The following is a description of a gene set: studied in species Homo sapiens Genes up-regulated in comparison of plasmacytoid dendritic cells (pDC) from influenza vaccinee pre-vaccination versus those at day 7 post-vaccination. from publication Nakaya HI, Wrammert J, Lee EK, Racioppi L, Marie-Kunze S, Haining WN, Means AR, Kasturi SP, Khan N, Li GM, McCausland M, Kanchan V, Kokko KE, Li S, Elbein R, Mehta AK, Aderem A, Subbarao K, Ahmed R, Pulendran B (PMID 21743478) Systems vaccinology has emerged as an interdisciplinary field that combines systems wide measurements and network and predictive modeling applied to vaccinology. Here we used the systems vaccinology approach to study the molecular mechanisms underlying th Human Gene Set: GSE29618_PRE_VS_DAY7_POST_LAIV_FLU_VACCINE_PDC_UP, and this is the list of marker genes: NRAP, MYH15, ALAS2, ALDH3A1, SERPINE1, FOXB1, CETN1, MUC13, ACVR2B-AS1, ZNF80, DSG1, MCOLN3, CLCN4, PDE7B, DHX58, NTRK2 (NCBI Gene Id 4915), SDF4, MEST, KIR2DL2, CD1E, LMX1B, HTR2C, MSMB, PRND, RNF126P1, CAV2, KCNIP2, SEZ6L2, DGKG, SPAG1, EDA2R, CYSLTR2, NEUROG2, ST20 (suppressor of tumorigenicity 20), LARP6, SOX10, GRB10, GPR135 (NCBI Gene Id 64582), LRRTM4, MPL, SMG6, CA3, AQP1, ZKSCAN5, EN1, AGR2, AFAP1, VPREB3, REPS1, HCG9, LYZL6, STAB2, FADD, ECM2, KIF25, PREP, PCGF1, PRDM14 (NCBI Gene Id 63978), IL17B, ARAP3, ROBO1, TMSB4Y, AMDHD2, ST8SIA1, CLUHP3, STC2, PALM, CEND1, BRINP1, SHANK2, ELL, THY1, ALX3, CYB561, HOXB7, ICOS, GNG3, WT1, LGALS14, CCL8, OR2B6 (NCBI Gene Id 26214), PER3, CPN1, GNAT3, HOXA5, PARP16, CDA, PRTN3, SIX5 (NCBI Gene Id 1754), F9, MAP3K9, LIFR, CACNG3 (NCBI Gene Id 10368), ACVR2B, IL1RAP, CCL21, EREG (NCBI Gene Id 2069), FXR2, GNAT1, HTN3, RAI14, DIRAS2, UBXN6, OR2C1 (NCBI Gene Id 81101), KCTD14, PRR5, KALRN, RAPGEF4, DHRS2, MCF2L, S100P, YBX2, FSCN2, IGFBP5, UCN, SGCG, OR7A17, CDC42EP1, WNT1, TACR1, TFCP2L1, GIMAP4, SLCO1A2 (solute carrier organic anion transporter family member 1A2), BCL11B, PASK, ZIC4, COL6A3 (NCBI Gene Id 1293), WDR55, MAST2 (NCBI Gene Id 23139), ZNF551, OR2F2, PITPNM3 (NCBI Gene Id 83394), BRINP3, RARB, KHK, HOOK1, SHOX2, ZNF428, SNTB1, TEAD1, HEG1, MYT1, PDLIM4, CHAT, STON1, SERPINC1, ESRRG, KLHL35, CKB, EPN3, RALGPS2, PRAMEF11 (PRAME family member 11), CALML5 (NCBI Gene Id 51806), SLC22A7, SERPINB4, CYLC2, AMHR2, CDKN2A-AS1, CILP, NCLN, RMND5A, SAMD9, RTL10, PLS1, ASIC3, GRN, AVPR1A, TNFRSF25, ARHGEF5, CD24, ETV1, TM9SF1, NHERF2, H2AC15, ARMC9, TDRKH, CXADR, MBL2, PLA2G3, AP1M2, SLC2A2, PRKD2, LEF1, GIPR, ADAMTS8 (NCBI Gene Id 11095), HTR1A, OSGIN1, PTGER3, DNASE2B, TM4SF1, GRIN2B, CXCL14, FLVCR2, RNF126, POLR3D, RAB3B